Given this list of marker genes SLC35A4, CNOT6, CSTB, ATG4B, GFI1B, LINC01750, NDUFAF6, NDUFS3, LRRC14B, FAM204A, ZCCHC24, RNVU1-15, FRY-AS1, FAM107B, HRG-AS1, STX18 (syntaxin 18), TMEM68, VEZT, SMG7-AS1, PKM, RUBCNL, RNU4-2, BRINP3, SNX16, FAM133B, IRX4, MAGI1, RNU4-13P, POLR2A (NCBI Gene Id 5430), TOB1-AS1, ZBTB4, SEMA4D, ISLR2, HRK, TENM4, CBR4-DT, RGS9, GPR78, CACNA1A, CDC42EP4, GATA3, NPR3, NME2, THAP4, BTN2A1, ZNF580, ZBTB10, CATSPERG, TFAP2A, MLH3, DICER1, ETS2, NR2F1-AS1, CALM3, MIR378A, ANTXR1, LINC01132, CXXC1, TCP11L1, ENSG00000227355, PITX3, FGF13, KNSTRN, ERICH6, ZMIZ1-AS1, SMAD3-DT, SMG1, PREX1, DHPS, ZMIZ1, ENSG00000228021, LINC01168, PCNX2, ENSG00000187951, OTUD1, NKD2 (NKD inhibitor of WNT signaling pathway 2), SMG7, SEMA3A, ENSG00000253593, NOTCH2NLA (notch 2 N-terminal like A), PPP5D1P, PRKCA, MICA, ARHGEF5, ARRB1, FOXP2, NR1D2, GNAS, TRAPPC9, CLBA1, MECOM, FST, BCL11B, MIR3124, GRK6, MIR4291, KRTAP1-3, GAD1, NECTIN2, SH3BP5L, ASPHD2, ARHGAP5, FAM217B, GDF11, TSHZ2 (teashirt zinc finger homeobox 2), CELF4, PAWR, ERICH6-AS1, PLD3, NR2F1, NOX5, ONECUT1, FAM227B, BRINP3-DT, SSBP2, FOXI1, TP53INP1, BUD23, KLF6, GS1-204I12.4 (NCBI Gene Id 105371653), TM4SF1, HUS1, DNAAF11, NBR2, TSC22D4, KBTBD4, PRKCE, SMARCD2, CLMN, NOVA1-DT, ZGPAT, SCARB1, CHRAC1, KCNG1, NOVA1, LRP6, METTL4, PHLDB1 (pleckstrin homology like domain family B member 1), BBX, F12, FGD3, ZNF253 (zinc finger protein 253), TRPS1, DTWD1, LINC01166, SYMPK, MEIS2, IQGAP2, TBC1D30, C19orf47, LAPTM4B, FAM241B, C2orf42, TOB1, AXIN2, COL6A3, RAB7A, ENSG00000242611, ARID2 (AT-rich interaction domain 2), ATL2, PLEKHA4, ZNF581, SYCP2, DDX55, TBKBP1, PUDPP2, FIGN, SPATS2L, ARFRP1, TUBB8, PRDM6, KMT5B, CAMK2N1 (NCBI Gene Id 55450), CATSPERE, SDC2, DPYSL3, SMAD3, APBB3, UFSP1, BRD7, PHF21A, PFKP, STX18-AS1, SLC16A5, ZFPM2, NDC80, MACROD1 (mono-ADP ribosylhydrolase 1), ODAD2, TPST1, PGAP1, DHRS13, AMD1, GPC6, CBR4, VSTM2A, ZNF350, ACO1, SLC25A6, KLHL22, BCL7A, ZNF114, MMP16, RNFT2, SELL, RPS19, ADAMTS9, SMAP2, SMAD5 (NCBI Gene Id 4090), BTN2A2, SOX6, HOXD11, STAU1, TG, TGFB3, ZNF512B, MMD, SHOX2, RPL5, DICER1-AS1, CEBPB-AS1, GPR158, ERN1 (endoplasmic reticulum to nucleus signaling 1), AMPD3, here is a description of the gene set: from publication Yevshin I, Sharipov R, Kolmykov S, Kondrakhin Y, Kolpakov F (PMID 30445619) species: Homo sapiens Genes containing one or more binding sites for (ZNF512B) in their promoter regions (TSS -1000,+100 bp) as identified by GTRD version 20.06 ChIP-seq harmonization. Human Gene Set: ZNF512B_TARGET_GENES